The following is a description of a gene set: studied in species Mus musculus from publication Tabula Muris Consortium (PMID 32669714) Mouse Gene Set: TABULA_MURIS_SENIS_LUNG_NON_CLASSICAL_MONOCYTE_AGEING, and this is the list of marker genes: Zfp36l1, Rpl6, Hp, Malat1, Apoc2, Cd52, Filip1l, Rel, Cd74, Rpl13, H2-Eb1, Rps7 (NCBI Gene Id 20115), Fcgr4, Xist, Nfe2l2, Scgb1a1, Mcemp1, Cybb, Apoe (apolipoprotein E), Fth1, Ly6a, Pla2g7, Fcer1g, H2-Aa, Sp140, Rpl13a, Txn1, Cox7a2l, Cfh, Cd81 (NCBI Gene Id 12520), Gda, Ifitm2, AW112010, Ms4a6c, H2-Ab1, Rps9, Cyba, Rps4x, Clec4e, Slpi, Il1b